Given this list of marker genes AK8, KITLG, USP47, LIPC, HIBADH (3-hydroxyisobutyrate dehydrogenase), MEIS2 (NCBI Gene Id 56908), KLF9, TLX1, FUT11, COL4A4, GPHB5, HES1, CYB5R2, HHEX, BCL9, MRPS6, RHOB, LUC7L3, FGF8, ZIC1, PNOC, ONECUT2, STAG2, ZFPM2, ZFP36L1, COL4A3 (NCBI Gene Id 200750), VXN, IL7, HOXA2, DUSP10, NDST4, TLK1, RPA3, EGR3, SP3, RIMS2, PHACTR3, PITX2, SIAH3, GNAO1, DCDC1, IGF2 (NCBI Gene Id 492304), SCP2D1, SLC43A3, SIKE1, ZNF503, LRCH2 (leucine rich repeats and calponin homology domain containing 2), CNOT7, NOG, KATNAL2, MGAT5B, CCNG1, CCL11, GRIK4, PPM1D, MYF6, MTSS1, TAB3, TCF21, TLE4, TRIB2 (NCBI Gene Id 28951), SNX1, CCND2, RARB, TFR2, DMD, EEF1A2, WDR1, NSD1, IGF2-AS, SLC2A14 (NCBI Gene Id 399494), RFX4, KHDRBS1 (KH RNA binding domain containing, signal transduction associated 1), LIF, HOXD9, RNF128, SPACA9, ABCB5, USO1, ZHX2, WNT9B, TFDP2, OTP, ZBTB18, SLITRK2, TSHZ2, LRMDA, PRL, HOXD10, MCTS1, OTX2, ABHD3, EML1, IRX4, PTHLH, TAFA1, EFNA5, TLE1 (NCBI Gene Id 7088), AMBN, SCRT2, ZFHX3, PABPN1, TBL1X, ZIC4, SMC6, THRA (thyroid hormone receptor alpha), AKAP12, MYPN, SIX1, GSK3B, TECTA, MR1, ADCYAP1, CIAO2A, GEN1, NOSIP, FGF13, HOXC11, PAX3, RC3H2, SPX, HOXD13, CDIN1, COL16A1, MMP1, EBF2, BEST4, SST, SMAD1, LMOD1, VPS37A, MEF2C, here is a description of the gene set: Human Gene Set: PBX1_02 Genes having at least one occurrence of the motif NNCATCAATCAANNW in the regions spanning 4 kb centered on their transcription starting sites. This matches the PBX1 transcription factor binding site V$PBX1_02 (v7.4 TRANSFAC). studied in species Homo sapiens